The following is a description of a gene set: from publication Lisiero DN, Soto H, Liau LM, Prins RM (PMID 21430221) species: Homo sapiens Genes up-regulated in Pmel-1 CD8 T cells: naïve versus primed with cognate antigen (gp100) and IL2. Human Gene Set: GSE22443_NAIVE_VS_ACT_AND_IL2_TREATED_CD8_TCELL_UP The expansion, trafficking and functional effectiveness of adoptively transferred CD8+ T-cells play a critical role in mediating effective anti-tumor immunity. However, the mechanisms which program the highly proliferative and functional state of CD8+ T-cells are not completely understood. We hypothesized that IL-12, a cytokine commonly induced by TLR activation, could enhance T-cell priming by altering responsiveness to antigen and cytokines. Priming of tumor specific CD8+ T-cells in the presence of IL-12 induced the acquisition of a 'polyfunctional' effector response and increased the generation of memory cells. Moreover, IL-12 priming also promoted high levels of the IL-2 receptor alpha-chain (CD25) and robust IL-2 mediated activation of STAT5. This sensitivity to IL-2 translated into enhanced in vivo proliferation of adoptively transferred CD8+ T-cells. Furthermore, real-time, in vivo imaging of T-cell trafficking confirmed the ability of IL-12 priming to drive in vivo proliferation. IL-12 priming enhanced the anti-tumor function of adoptively transferred cells by reducing established subcutaneous tumor burden, and significantly increasing survival in an established intracranial tumor model. Finally, IL-12 priming of human PBMCs generates tumor specific T-cells phenotypically and functionally similar to IL-12 primed Pmel-1 T-cells. These results highlight IL-12 as an important mediator of CD8+ T-cell effector function and anti-tumor immunity., and this is the list of marker genes: BTG2, TECTA, TMEM30B, CLU, ZP2 (NCBI Gene Id 7783), FCER2, IL4I1, FAM171A1, SLC12A3, NUPR1, RALA, SLC27A1, KIF9, C6orf136, ASPRV1, KLRG1, TNFRSF9, CYP1A2, RNF19B, REEP1, CCL17, MAP3K6, CDR2, EMP2, SRI, SHROOM3, NDRG4, SRGN, FOXQ1, SPRYD7, HLA-B, IL12A, DNAJB1, PNLIPRP1, CYP8B1, FOXA1, FAM3D, TECTB, AMBP, ENTPD2, GREM2, SLC44A1, MRPS5, CKMT1B, WFDC2, TNNI1, ALOX12B, TWSG1, PLSCR1, LRATD1, TNF, GRPEL2, TMPRSS2, ZG16, AMOT, RHOC, B4GALNT2, ALDH1A3, CISD1, LIMS4, ST3GAL5, BPIFA2, PDCD4, SEMA4F, NEFH, CST8, GADD45A, MYCL, GFPT2, CYP11A1, ADCY8, DMBT1, ELN, FABP9, FHOD3, TMEFF1 (transmembrane protein with EGF like and two follistatin like domains 1), MSLN, CALML5, NFKB2, ACAD9, OSBPL5, SLC7A3, FABP2, COL5A2, PIPOX, MST1R, DDX5, ARHGEF28, GJA1 (gap junction protein alpha 1), SEMA7A, GNB4, DNAJB4, VWF, PSMA1, GIPC2, PLD1, IL18R1, GSTT1, PXK, NREP, FABP4, HAS2, WNT11, GCLC, RESP18, CACNA1S, PDLIM4, HSP90AA1, VPS37C, CCR7, PDE9A, PDS5B, CA8, MLLT11, GSTA5 (NCBI Gene Id 221357), TNNC1, PLG, OCM2, APOA4, MLF1, KLK6, HGF, RGS5 (NCBI Gene Id 8490), CMTM8, CRHR1, SURF1, SERPINB2 (serpin family B member 2), C4BPA, TIMP3, FOXJ1, CSF2, CIDEB, EFNA1, SULT2B1, SMAD1, FOXA2 (NCBI Gene Id 3170), SCIN, SLC51A, HBE1, FEZF2, CIDEC, SGCG, CLDN1, MADCAM1, TFF3, SCEL, IFIT1B, SOX7, GUCY2C, AHCYL1, ADH1C, PTPRG, EMP1, ADPRM, KRT12, MYO1B, ITIH4, GRIA3, BPIFB1, CALML4, RBBP7, RLN1, FERMT2, MYL2, MED10, IGFALS, CPXM2, TNFRSF4, LIMA1, PTPN1, CRYBG1, TNFRSF17, CRYAA (NCBI Gene Id 1409), TRAF3IP2, PLAT, NPY, APOD, ARL6, PRPH, PLK2, TSPAN6, WNT10B (Wnt family member 10B), NFKBIB, INHBB, UMOD, SPARCL1, ING1, DKK2, AGT, WWC1, SIX1, TNNT2, KRT10, KLF4, NSMCE1 (NSE1 homolog, SMC5-SMC6 complex component), ELF3, CYB561, BTBD3, ASNS, SCT